Given this list of marker genes GPC3, MEIS2 (NCBI Gene Id 56908, Meis homeobox 2), BMPR1B, IRX5, TBX5, SRCAP, HOXD13, RUNX2, MYCN, IFT140, KIF15, FIG4, GPC4, NSDHL, ERF (ETS2 repressor factor), GDF5, COL2A1, BMP2 (bone morphogenetic protein 2), INTU, here is a description of the gene set: Aplasia/Hypoplasia of the 2nd finger species: Homo sapiens Human Gene Set: HP_APLASIA_HYPOPLASIA_OF_THE_2ND_FINGER A small/hypoplastic or absent/aplastic 2nd finger.